Given this list of marker genes Ppp1r9a, Kif2c, Srcin1, Arf1, Wasf2 (NCBI Gene Id 52063), Wasl, Abi2, Myh10, Nefh (NCBI Gene Id 380684), Adgrb1, Actb, Actr3, Farp1, Nefl, Dbn1, Sipa1l1, Actn2, Ezr, Ina, Sh3gl2, Nos1ap, Frmpd4, Arhgef7, Dbnl, Rock2, Rac3, Rac1, Cpne6, Cit, here is a description of the gene set: studied in species Mus musculus A process that is carried out at the cellular level which results in the assembly, arrangement of constituent parts, or disassembly of cytoskeletal structures comprising cytoskeletal filaments and their associated proteins in the postsynaptic cytoskeleton. Mouse Gene Set: GOBP_POSTSYNAPTIC_CYTOSKELETON_ORGANIZATION